The following is a description of a gene set: Mouse Gene Set: REACTOME_PROTEIN_HYDROXYLATION Protein hydroxylation studied in species Mus musculus, and this is the list of marker genes: Jmjd7, Rps23, Rccd1, Kdm8, U2af2 (NCBI Gene Id 22185), Rpl8, Drg2, Drg1, Ogfod1 (NCBI Gene Id 338347), Jmjd6 (jumonji domain containing 6), Etf1, Rps6, Rpl27a (NCBI Gene Id 26451), Rwdd1, Riox1, Riox2, Jmjd4, Zc3h15